Given this list of marker genes SEC13, KNTC1, DSN1 (NCBI Gene Id 79980), PAFAH1B1, DYNC1LI1, NUP37, KIF2A, NEK7, TUBB8, PPP2R5A (NCBI Gene Id 5525), CLASP2, SGO2, CENPI, XPO1, SEH1L, CENPM, TUBA1B, AURKB, TUBB4B, RANGAP1, NEK9, RCC2, DYNC1I2, DYNLL2, PPP1CC, TUBAL3, PPP2R5E, TUBB2A, BIRC5, B9D2, DYNC1H1, CENPS, PPP2CB, EML4, CLIP1, BUB1, CENPC, CENPH, SGO1, DYNC1LI2, TUBB1, MAD2L1, TUBA3C, BUB3, ERCC6L, SKA1, RANBP2, NEK6, NUF2, CENPU, TUBB4A, SPC25, PLK1, TUBB6, NDC80, NDEL1, MIS12, CDC20, SPDL1, TUBA4A, NUP160, INCENP, CKAP5 (cytoskeleton associated protein 5), DYNC1I1, TUBA3D, DYNLL1, RPS27, CENPK, PPP2R1A, TUBA4B, NUP85, KIF2B, KIF18A, PPP2R5C, NUP107, AHCTF1, CENPE, NDE1, TUBB8B, ITGB3BP, PPP2CA (protein phosphatase 2 catalytic subunit alpha), CENPL, TUBA1A, ZW10, PPP2R5D, CDCA8, SKA2, CENPT, TUBA3E, TUBB2B, NSL1, CENPF, NUP98, CENPO, TUBA1C (tubulin alpha 1c), CLASP1, NUDC, SPC24, CENPP (centromere protein P), ZWILCH, TUBB3, TAOK1, PPP2R1B, PMF1, CENPA, CENPQ, PPP2R5B, KIF2C, NUP43, CENPN, TUBA8, MAD1L1, ZWINT, NUP133, BUB1B, MAPRE1, KNL1, here is a description of the gene set: Reactome Pathway: EML4 and NUDC in mitotic spindle formation part of: Mitotic Prometaphase species: Homo sapiens EML4 and NUDC proteins are required for mitotic spindle formation, attachment of spindle microtubule ends to kinetochores, and alignment of mitotic chromosome at the metaphase plate. EML4 is a WD40 family protein that binds to interphase microtubules and stabilizes them. At mitotic entry, EML4 undergoes phosphorylation by serine/threonine kinases NEK6 and NEK7, leading to its dissociation from microtubules, which is necessary for the assembly of a dynamic mitotic spindle. EML4, through its WD40 repeats, interacts with NUDC and recruits it to the kinetochores of the mitotic spindle. It is possible that other mitotic kinases, besides NEK6 and NEK7, also phosphorylate EML4. Phosphorylation of different residues of EML4 could reduce or increase affinity of EML4 for specific subpopulations of microtubules in mitosis.<br>A recurrent genomic rearrangement, reported in about 5% cases of non-small cell lung cancer (NSCLC) fuses the N-terminal portion of EML4 with the C-terminal portion of ALK (anaplastic lymphoma kinase), resulting in a constitutively active ALK.